The following is a description of a gene set: studied in species Homo sapiens Human Gene Set: GOBP_NEUROTRANSMITTER_RECEPTOR_TRANSPORT_ENDOSOME_TO_POSTSYNAPTIC_MEMBRANE The directed movement of neurotransmitter receptor from the postsynaptic endosome to the postsynaptic membrane in transport vesicles., and this is the list of marker genes: LRRC7, GRIP2, RAB8A, GRIP1, VPS35, NSG1, ARHGAP44, VAMP4, RAB11A, GRIPAP1, SCRIB